Given this list of marker genes Opn3, Rlbp1, Rho, Opn4, Opn5, Abca4, here is a description of the gene set: studied in species Mus musculus Binding to 11-cis retinal, an isomer of retinal that plays an important role in the visual process in most vertebrates. 11-cis retinal combines with opsin in the rods (scotopsin) to form rhodopsin or visual purple. Retinal is one of the three compounds that makes up vitamin A. Mouse Gene Set: GOMF_11_CIS_RETINAL_BINDING